The following is a description of a gene set: Human Gene Set: REACTOME_ELEVATION_OF_CYTOSOLIC_CA2_LEVELS species: Homo sapiens Elevation of cytosolic Ca2+ levels, and this is the list of marker genes: ITPR2, P2RX7, TRPC6, P2RX2, ORAI1, ORAI2, ITPR3, P2RX5, P2RX6, ITPR1, P2RX3, STIM1, TRPC7, P2RX4, TRPC3, P2RX1